The following is a description of a gene set: species: Homo sapiens Human Gene Set: REACTOME_DOWNREGULATION_OF_TGF_BETA_RECEPTOR_SIGNALING Downregulation of TGF-beta receptor signaling, and this is the list of marker genes: UBA52, TGFB1, SMAD3, PPP1CA, USP15, PMEPA1, UBC, NEDD4L, ZFYVE9, UBB, TGFBR2, SMAD7, PPP1CC, SMURF1, SMURF2, BAMBI, TGFBR1, UCHL5, STUB1, SMAD2, MTMR4, RPS27A, STRAP, PPP1CB, XPO1, PPP1R15A